The following is a description of a gene set: Genes up-regulated in monocyte-derived dendritic cells: untreated versus vehicle. species: Homo sapiens Human monocyte derived dendritic cells matured via galectin-1 or LPS. from publication Fulcher JA, Hashimi ST, Levroney EL, Pang M, Gurney KB, Baum LG, Lee B (PMID 16785517) Human Gene Set: GSE4984_UNTREATED_VS_VEHICLE_CTRL_TREATED_DC_UP, and this is the list of marker genes: SLC29A2, ESR1, MCCC1, SARAF, RGL2, TUG1, CEP164, FAM216B, FAM124B, FAM169BP, DSE, TNFAIP8L1, IMPDH1, ULK3, FBXL20, ITGA5, KIFC3, HSH2D, SHF, MTM1 (myotubularin 1), ZHX1, CARD11, KCNJ13, FAM3A, ELL, DTX4, HSD11B1, RASGRP3, NAT1, RPLP2, CD248, EEIG1, YPEL3, NR3C1, TOM1L2, KMT2B, CBX4, CREBL2, BEND4, SERF2, CCDC88B, EXD2, ANKRD55, FAU, ST3GAL1, FBXW4, ADH4, CERS6, CD2AP, TTC7A, SELPLG, TLR9, MLYCD, APP, MR1, PRICKLE3, TBC1D20, PCIF1, GPKOW, UTP25, PPIC, PPARGC1B, GPR34, MTR, HDAC10, NFE2L2, TLR6, RPH3AL, BMF, CDC42EP5, HDAC4, WDR13, CELSR1, FRS2, SYNRG, MIR29A, SETD1B, TBXA2R, MYORG, RFX5, AIF1, HYKK, UBE2R2, TMEM270, LIMD1, NT5E, DCAF12, GRK2, ANTXR2, CCN4, CREB1, NCKAP1L, SLC45A2, ARHGAP35, B4GALT1, HSD17B8 (hydroxysteroid 17-beta dehydrogenase 8), TOP1MT, RPL12, PIK3C3, CCL2, ORAI2, ACSS2, SNRK, RPRD2, SLC17A2, ITPR2, ZFYVE1, DYRK1A, GRK6, ARNT, MS4A1, DNMT3A, BSDC1, TCF12, FLNA, TNFRSF1A (NCBI Gene Id 8077), ADCK2, IL12A, KPNA4, RLF, RAB11FIP1, CERT1, GNS, ACVRL1, OTULINL, MBD5, ACOX3, C1QC, ATXN3, FBXO38, NSA2, FBXO11, UBASH3A, EPC1, ACSS1, CHD4, KCNH2, GAL3ST3, CAPN15, OAS3, RNF34, CRY2, SNX30, TSC1, CASD1, CNKSR3, ITPKC, RDH10, CALCRL (NCBI Gene Id 10203), CDC14B, POMGNT1, MIR7-2, TSPAN15, SIPA1L2, DNAJC6